Given this list of marker genes LEF1, TGFB1, SFMBT1, FGF3, USP19, LUC7L, BMP4, SOX15, YBX3, FGF8, TWIST1 (NCBI Gene Id 7967), SIRT2, here is a description of the gene set: Any process that stops, prevents, or reduces the frequency, rate or extent of muscle development. Human Gene Set: GOBP_NEGATIVE_REGULATION_OF_MUSCLE_ORGAN_DEVELOPMENT species: Homo sapiens